The following is a description of a gene set: Human Gene Set: GOBP_SPINAL_CORD_ASSOCIATION_NEURON_DIFFERENTIATION species: Homo sapiens The process in which neuroepithelial cells in the neural tube acquire specialized structural and/or functional features of association neurons. Association neurons are cells located in the dorsal portion of the spinal cord that integrate sensory input. Differentiation includes the processes involved in commitment of a cell to a specific fate., and this is the list of marker genes: PAX7 (paired box 7), GSX2, WNT3A, GSX1, GDF7, ASCL1, WNT1, LHX5, MDGA1, TAL1, LHX1, LHX3, LMO4